The following is a description of a gene set: Human Gene Set: GSE2770_TGFB_AND_IL4_VS_TGFB_AND_IL12_TREATED_ACT_CD4_TCELL_48H_UP from publication Lund R, Aittokallio T, Nevalainen O, Lahesmaa R (PMID 14607935) studied in species Homo sapiens Genes up-regulated in CD4 T cells activated by anti-CD3 and anti-CD28: TGFB1 and IL4 (48h) versus TGFB1 and IL-12 (48h). Th1 and Th2 cells arise from a common precursor cell in response to triggering through the TCR and cytokine receptors for IL-12 or IL-4. This leads to activation of complex signaling pathways, which are not known in detail. Disturbances in the balance between type 1 and type 2 responses can lead to certain immune-mediated diseases. Thus, it is important to understand how Th1 and Th2 cells are generated. To clarify the mechanisms as to how IL-12 and IL-4 induce Th1 and Th2 differentiation and how TGF-beta can inhibit this process, we have used oligonucleotide arrays to examine the early polarization of Th1 and Th2 cells in the presence and absence of TGF-beta after 0, 2, 6 and 48 hours of polarization., and this is the list of marker genes: KCTD17, KLHL9, KCTD13, DCAF10, SLC48A1 (NCBI Gene Id 55652), CPSF1, GINS4, TTBK2, ATRIP, HCFC1R1, FANCI (NCBI Gene Id 751608), PIP5K1C, SKIC8, RPL36, GMCL1, PRPF40B, SHPRH, CEP83, LDAH, GPAT4, GPAM, TAF10, PHKB, PRKAG2, PRPF6, ASCC1, ZNF280B, ERC1, TUBG2, TNFRSF19, R3HCC1, PIGQ, SNAP29, THAP9, IARS2, CCNB1IP1, RUSC1 (RUN and SH3 domain containing 1), CRYBG2, BOD1L1, C2orf74, PSMC3, NFS1, H2AC6, NUDCD3, SLC45A1, ZKSCAN5, SPG11, ACAD8 (NCBI Gene Id 27034), THOC1, LSM10, AP2M1, TECR, FTL, ATF6, CLTCL1, RPL13P5, GABBR1, SCFD2, MGA, MED25, FBF1, GALE, ZNF605, RFX2, PDE6D, MYL6B, C6orf163, ZNF559, MEX3D, ZFP90, RAB7A, AGPAT1, EIF2S3, PPM1F, LAMTOR1, TMEM52, SNAPIN, RFC4 (NCBI Gene Id 5984), UBE2V2, PDZK1P1, STRADB, OSTM1, CSTB, PUS3, SMG5 (SMG5 nonsense mediated mRNA decay factor), LRWD1, FRS2, POLR1A, TBC1D8, DTD2, RPAP1, ATOX1, RAB5B, ARMC10, NTHL1, GFOD3P, PTER, RBM34, SNHG11, FANCF, XRCC1, GKAP1, FBXW12, EEF1AKMT3, COPS7B, TMEM134, PRKCB, CASC3, PRPF3, YTHDF2, RCN3, DNAJC13 (NCBI Gene Id 285196), DCLRE1A, PGD, CCDC77, LZTFL1, RAD52, SNORA21, PCBD2, WDR89, PRDX3, SMCR8, ZC3H10, TTC14, COQ9 (NCBI Gene Id 57017), TIMM9, PILRB, SLC25A23, CCDC71L, CCDC90B, GPR155, METTL26, CCT3, ZFAND1, RELL2, ZNF277, ALDOC, GATB, C8orf88, FPGS, MALAT1, IFNGR1, PMS2P9, OXLD1, ACSF2, CFAP184, FOXJ3 (NCBI Gene Id 22887), MFSD4B, MYG1, CCDC18-AS1, TBC1D13, PUF60, COA7, SNAPC1, SLC2A6, COQ10A, BIVM, GPR180, UCN, SFT2D3, MCM3AP, MEF2A (NCBI Gene Id 4205), PFDN6, DCTN4, BBOF1, SEPTIN4, VPS29, MIR600HG, MAD2L2, NDFIP2, FXYD7, ABITRAM, PCNX4, KIAA0408, CEP19 (NCBI Gene Id 84984), VPS25, NCAPD2, MANBAL, NAT9, GTPBP2, SLC22A5, STMP1, FAHD2A, TULP4, MRS2, AKAP17A (NCBI Gene Id 8280), MYH3, BLCAP, TMEM177, GPR108, COX16 (NCBI Gene Id 51241), BAD, ABTB3, KRI1, SSBP3, NUDT9, DLG1, ZNF540